The following is a description of a gene set: The orderly movement of a Schwann cell from one site to another. A Schwann cell is a glial cell that ensheathes axons of neuron in the peripheral nervous system and is necessary for their maintenance and function. Mouse Gene Set: GOBP_SCHWANN_CELL_MIGRATION species: Mus musculus, and this is the list of marker genes: Tiam1, Ptprz1, Cers2, Vim, Nf1, Pmp22, Rras, Rras2, Fubp1, Pi4ka, Grin1 (glutamate receptor, ionotropic, NMDA1 (zeta 1)), Fas, Lrp1